The following is a description of a gene set: studied in species Mus musculus Any process that modulates the frequency, rate or extent of action potential creation, propagation or termination in a ventricular cardiac muscle cell contributing to the regulation of its contraction. This typically occurs via modulation of the activity or expression of voltage-gated ion channels. Mouse Gene Set: GOBP_REGULATION_OF_VENTRICULAR_CARDIAC_MUSCLE_CELL_ACTION_POTENTIAL, and this is the list of marker genes: Dlg1, Dsp, Dsc2, Bin1, Jup, Ryr2, Pkp2, Trpm4, Cacna1c, Cav1, Ctnna3, Dsg2